Given this list of marker genes F2, Itgb3, Slc24a2, Htt, Capn3, Gimap3, Adra1a, Grin2a, Chd7, Jsrp1, Trpv2, Ddit3 (DNA-damage inducible transcript 3), Ppp3r1, Fyn, P2rx4, Grin1, Tmbim6, Cacna1e, Ppp3ca, Ccl21e, P2rx7, Pml, Akap5, Grin2b, Trpv1, Thy1, Cd4, Prnp, Agtr1a (NCBI Gene Id 72294), Trpm2, Ero1a, Sri, Trpc3, Slc8a3, Htr2c (5-hydroxytryptamine (serotonin) receptor 2C), Ppp3cc, Nol3, Ccl19-ps6, F2r, Letm1, Cyba, Plcb1, Trdn, Grin2c, Atg5, Hrc, Prkce, Kcnn4, Lime1, Nalf2, Cxcr3, Tpcn2 (two pore segment channel 2), Trpv6, Ryr3, Jph3 (junctophilin 3), Htr2b, Pln, Slc24a4, Cacna1a, Cemip, Ptprc, Trpm1, Trpa1, Lyn, P2rx1, Lhcgr, Cd19, Mettl21c, Adrb1, Ghitm, Cacna1s, Gp1bb, Ccr5, P2rx5, Pde4d, Fcrl5, Cacna1d, Jph2, Ccl19-ps4 (C-C motif chemokine ligand 19, pseudogene 4), Drd1, Plch2, Plcb4, Gimap5, Hap1 (NCBI Gene Id 268486), P2ry6, Tmem38a, Selenon, Adcyap1r1, Cacna1b, Htr2a, Plcl1, Trpv4, Trpv3, Snca, Ptpn6, Gsto1, Itpr1, Cxcl9, Ccl21f, Ubash3b, Diaph1, Trpv5, Gstm7 (NCBI Gene Id 99761), Cacna1i, Cacna2d1, Akap6, Itpr3, Abl1, Itgav, Trpc1, Cacna1g, Ccl19-ps1, Tgfb1, Casq2, Il13, Adrb2, Aplnr, Pkd2, Cav1, Camk2d, Plch1, Fkbp1b, Cxcl11, Ccl19, Fasl, Cacnb3, Bcl2 (NCBI Gene Id 98734), Plcg1, Slc8a2, Cacna1c, Tgfb2, Gp1ba, Ms4a1, Drd2, Fgf2, Bdkrb1, Dmd, Ccl19-ps3, Ccl3, Ntsr1, Ffar1, Ppp3r2, Myo5a, Ccn2, Itpr2 (inositol 1,4,5-triphosphate receptor 2), Fkbp1a, Clec4b1, Cxcl10, Prkd1, Pawr, Slc8a1, Cx3cl1, Dbi, Ank2, Dhrs7c, Ptk2b, Plcb2, Gper1, Grin2d, Plce1, Xcr1, Ngf, Ccl21a, Plcb3, Ppp3cb, Slc8b1, Flna, Calm2, Ednra, Npsr1, Epo, Ccl19-ps5, Cacna1f, Bak1, Ryr1, Tmem38b (transmembrane protein 38B), Lck, Ibtk, Mcoln1, Calm3, Bmp4, Asph, Plcg2, Grm6, Ms4a2, Oga, Cherp, Glp1r, F2rl3, Casq1, Pdpk1, Xcl1, Calm1, Plcl2, Nalf1, Bax, Gp9, Ryr2, Coro1a, Ccl21b, Gp5, Ccl21d, Gpr39, here is a description of the gene set: A process in which a calcium ion is transported from one side of a membrane to the other into the cytosol by means of some agent such as a transporter or pore. species: Mus musculus Mouse Gene Set: GOBP_CALCIUM_ION_TRANSMEMBRANE_IMPORT_INTO_CYTOSOL